The following is a description of a gene set: studied in species Homo sapiens Any process that activates or increases the duration or quality of sleep, a readily reversible state of reduced awareness and metabolic activity that occurs periodically in many animals. Human Gene Set: GOBP_POSITIVE_REGULATION_OF_CIRCADIAN_SLEEP_WAKE_CYCLE_SLEEP, and this is the list of marker genes: GHRH, NPY2R, MTNR1B, ADORA2A, GHRL, GHRHR